Given this list of marker genes SLC1A5, SLC32A1, SLC7A8, SLC6A9 (solute carrier family 6 member 9), SLC1A6, SLC7A9, SLC38A5, SLC38A2, SLC38A1, SLC43A1, SLC6A7, SLC38A9, SLC6A18, SLC25A38, SLC1A1, SLC7A10, SLC6A6, SLC25A12, MFSD12, SLC38A6 (NCBI Gene Id 145389), SLC36A2, SFXN1, SLC1A7, SLC36A4, SLC1A3, SLC6A14, SLC36A3, SLC43A2, SLC38A4, SLC6A19, SLC36A1, SLC6A5, SLC1A2, SLC25A13, SLC6A20, SLC38A3, SLC6A15, SLC3A2, SLC1A4, SLC7A5, SLC38A7, here is a description of the gene set: Enables the transfer of neutral L-amino acids from one side of a membrane to the other. Neutral amino acids have side chains with no charge at pH 7.3. studied in species Homo sapiens Human Gene Set: GOMF_NEUTRAL_L_AMINO_ACID_TRANSMEMBRANE_TRANSPORTER_ACTIVITY